The following is a description of a gene set: Any process that modulates the frequency, rate or extent of epithelial cell differentiation involved in kidney development. Human Gene Set: GOBP_REGULATION_OF_EPITHELIAL_CELL_DIFFERENTIATION_INVOLVED_IN_KIDNEY_DEVELOPMENT studied in species Homo sapiens, and this is the list of marker genes: GATA3, WWTR1, LHX1, PROM1, OSR1, YAP1, CTNNB1, PAX8, CD24, LIF, GDNF, PRKX, MMP9, STAT1, WNT9B, PAX2